Given this list of marker genes Mesp1, Smarcd3, Tbx5, Pcdha9, Hand2, Hand1, Notch1, Nkx2-5, Mef2c, here is a description of the gene set: species: Mus musculus Mouse Gene Set: GOBP_CARDIAC_VENTRICLE_FORMATION The developmental process pertaining to the initial formation of a cardiac ventricle from unspecified parts. A cardiac ventricle receives blood from a cardiac atrium and pumps it out of the heart.